The following is a description of a gene set: Human Gene Set: PID_TCR_PATHWAY species: Homo sapiens TCR signaling in naïve CD4+ T cells from publication Schaefer CF, Anthony K, Krupa S, Buchoff J, Day M, Hannay T, Buetow KH (PMID 18832364), and this is the list of marker genes: WAS, CD28, NRAS, IKBKB, GRB2, PTEN, ITK, FYN (FYN proto-oncogene, Src family tyrosine kinase), CHUK, CD3D, PAG1 (NCBI Gene Id 55824), PTPN11, NCK1, RASGRP1, CD4, HLA-DRA, SHC1, CD3E, PRKCA, CSK, TRAF6, AKT1, FLNA, FYB1, RASSF5, CARD11, CDC42, MAP3K14, CD247, STIM1, CD80, CD3G, VAV1, SLA2, CBL, PLCG1, SH3BP2, GRAP2, MAP4K1, KRAS, CD86, IKBKG, LCK, MAP3K8, ZAP70, PRKCE, ORAI1, GAB2, PRKCQ, SOS1, HRAS (HRas proto-oncogene, GTPase), BCL10, TRPV6, STK39, PRKCB, RAP1A, PTPRC, DBNL, PDPK1, PTPN6, LCP2, MALT1, LAT, RASGRP2 (NCBI Gene Id 10235)